The following is a description of a gene set: Human Gene Set: KEGG_MEDICUS_REFERENCE_STEROID_HORMONE_BIOSYNTHESIS_PROGESTERONE_TO_CORTISOL_CORTISONE Pathway Definition from KEGG: Progesterone -- CYP17A1 >> CYP21A2 >> CYP11B1/2 -> Cortisol -- HSD11B2 -> Cortisone Steroid hormone biosynthesis, progesterone to cortisol/cortisone. Pathway ID: N00338. Pathway type: Reference. Pathway class: nt06019 Steroid hormone biosynthesis. studied in species Homo sapiens, and this is the list of marker genes: CYP11B2, HSD11B2, CYP17A1, CYP21A2, CYP11B1